The following is a description of a gene set: studied in species Homo sapiens Any process that stops, prevents, or reduces the frequency, rate, or extent of interleukin-1 alpha production. Human Gene Set: GOBP_NEGATIVE_REGULATION_OF_INTERLEUKIN_1_ALPHA_PRODUCTION, and this is the list of marker genes: MIR181C, MIR181A2, IL1R2, CX3CL1, MIR142